The following is a description of a gene set: species: Homo sapiens The process in which the anatomical structure of the retina is generated and organized. Human Gene Set: GOBP_RETINA_MORPHOGENESIS_IN_CAMERA_TYPE_EYE, and this is the list of marker genes: NTRK2, PRDM1, FAT3, LARGE1, CRB1, IHH, PTPRM, VSX1, SAMD7, NAGLU, CDON, MFSD2A, ROM1, SOX8, ARL6 (NCBI Gene Id 84100), THY1, HIPK1, HCN1, RBP4, DLL1, TTC8, PDE6C, ZHX2, RDH13 (retinol dehydrogenase 13), FJX1, RPGRIP1, CRB2, SDK1, CNTF, SAMD11, PROX1, NECTIN3, BBS10, NOTCH1, IRX5, RHO, HIPK2, FOXN4, ATP8A2, AHI1, CALB1, TFAP2A, LHX1, DIO3, RPGRIP1L, THRB, GNAT2, RP1, PTF1A, STAT3, SLC1A1, IMPG2, SOX9, RS1, SDK2, NRL, CABP4, DSCAM, TFAP2B, NDP (NCBI Gene Id 4693), TSPAN12, USH1C, RORB, BBS4, GNAT1, MAN2A1, PROM1, VSX2, LRP5, MEGF11